The following is a description of a gene set: species: Homo sapiens Human Gene Set: GOBP_THYROID_HORMONE_TRANSPORT The directed movement of thyroid hormone into, out of or within a cell, or between cells, by means of some agent such as a transporter or pore., and this is the list of marker genes: CRYM, SLCO1B1, SLC16A2, SLC16A10, SLC17A4, SLCO1C1, SERPINA7, SLCO4A1, SLC3A2, TUBB1, SLC7A5, SLC7A8 (NCBI Gene Id 23428)